The following is a description of a gene set: studied in species Mus musculus Mouse Gene Set: GOBP_REGULATION_OF_ADHERENS_JUNCTION_ORGANIZATION Any process that modulates the frequency, rate or extent of adherens junction organization., and this is the list of marker genes: Rdx, Add1, Ptpn23, Bmp6, Vegfa